The following is a description of a gene set: species: Mus musculus Mouse Gene Set: chr5E5, and this is the list of marker genes: Nudt9, Lpcat2b, Gm8152, C230066G23Rik, Lrrc8d, Aff1, Gm19566, Klhl8, Lrrc8c, Gm33474, Gm8365, Rpap2, Gbp8, Hfm1, Arhgap24, 4930429D17Rik, Gm32921 (NCBI Gene Id 102635633), Spp1, Rps15a-ps5, Barhl2, Abcg3, Gbp10, Gm29707, Gm38433, Thoc2l, Gm8200, Mapk10 (mitogen-activated protein kinase 10), Mir5619, 1700016H13Rik, Gm5870, 1700013M08Rik, Ephx4, Gm18702, Gm26703, Gm17202, n-R5s173, Zfp951 (NCBI Gene Id 626391), Olfr719-ps, Gm8258, Hsd17b11 (hydroxysteroid (17-beta) dehydrogenase 11), Scpppq1, 5430427N15Rik, Btbd8, Slc10a6, Brdt, Gm25721, 4930458A03Rik, Gm8145, Gm9727, Lrrc8dos, Gm32736, 4930432H08Rik, Zfp644, Gbp4, Gm17978, Gm17937, Gm22557, Gm28050, Wdfy3, Ibsp, Ptpn13, Mepe, Gm31048, Pkd2, Gm10359, Sparcl1, Gbp6, Glmn, Gbp9, Hsd17b13, Lrrc8b, Dspp, Cdc7, Dmp1, Tgfbr3, Gm32051, 1700028K03Rik, Zfp326, Gbp11, Gm5987, Gm42141, 1700021F02Rik